The following is a description of a gene set: Pubertal genes down-regulated by TGFB1. Expression microarray analysis identified over genes regulated during puberty in the mouse mammary gland. Most prominent were genes whose expression increased in parallel with pubertal development and remained high thereafter. Members of the Wnt, transforming growth factor-beta and oestrogen-signalling pathways were significantly overrepresented. Comparison to expression data from CITED1 knockout mice identified a subset of oestrogen-responsive genes displaying altered expression in the absence of CITED1. Included in this subset are stanniocalcin2 (Stc2) and amphiregulin (Areg). Chromatin immunoprecipitation revealed that ERalpha binds to oestrogen response elements in both the Stc2 and Areg genes in the mammary gland during puberty. Additionally, CITED1 and ERalpha localize to the same epithelial cells of the pubertal mammary gland, supporting a role for interaction of these two proteins during normal development. In a human breast cancer data set, expression of Stc2, Areg and CITED1 parallel that of ERalpha. Similar to ERalpha, CITED1 expression correlates with good outcome in breast cancer, implying that potential maintenance of the ERalpha-CITED1 co-regulated signalling pathway in breast tumours can indicate good prognosis. Human Gene Set: MCBRYAN_PUBERTAL_TGFB1_TARGETS_DN from publication McBryan J, Howlin J, Kenny PA, Shioda T, Martin F (PMID 17486082) species: Mus musculus, and this is the list of marker genes: AREG, SFTPD, TYR, APOC2, CHI3L1, SLC12A2, LCN2, CD9, PHLDA1, CLDN4, PTX3, PFN2 (profilin 2), SFTPB, SFRP1, GZMA, PPP1R3C, EDNRA, GCLC, CDH1, APOD, SLPI, NHERF1, NFKB2, NID1, CSN3, NID2, BCL6, PTTG1, VWF, ID4, IDH1, TCF7, TNFAIP2, PLPP2, PTN, VAPB, SOD2, RBM5 (NCBI Gene Id 10181), ERBB3, MBTPS1, KITLG, BCL3, KLF5, RBBP4, GATA3, JCHAIN, PDK4, RAB27B, ADM, DAPK1, ARHGEF3, MT1X, RGS2, HSPA1B, IFIT3, PTGIS, LRP5, ABCC3, ID2, CDH5, ALDH1A1, SPINT2